Given this list of marker genes MYO5B, TMEM216, TNPO3, SPRY4, MYO19, CD164, SEPTIN3, MBD1, LPP, ARHGEF39, SLC9A2, FRYL, TSPOAP1, PAQR7 (progestin and adipoQ receptor family member 7), SPRTN, DCP1B, CDC16, PAXBP1, YWHAZ, CCNJL, CLEC12A, VEGFA, GMEB1, ALOX15, PDZD2, RETREG2, ENSG00000255537, CTSE, SMIM43, RFX3, MICAL3 (NCBI Gene Id 729269), RELN, FAM86B1, TRPM3, EXPH5, BOLL, VDAC3, OPA1, C10orf53, CD207, TRARG1, ZNF746, BBX, CALB1, here is a description of the gene set: studied in species Homo sapiens Genes predicted to be targets of miRBase v22 microRNA hsa-miR-4648 in miRDB v6.0 with MirTarget v4 prediction scores > 80 (high confidence targets). Human Gene Set: MIR4648 from publication Chen Y, Wang X (PMID 31504780)